Given this list of marker genes SLC11A1, SLC39A8, SLC30A1, ABCB6, MT3, here is a description of the gene set: studied in species Homo sapiens Any process that reduces or removes the toxicity of cadmium ion. These may include transport of cadmium away from sensitive areas and to compartments or complexes whose purpose is sequestration of cadmium ion. Human Gene Set: GOBP_DETOXIFICATION_OF_CADMIUM_ION